Given this list of marker genes FGFR1, RUNX2, MAPK12, IGFBP3, CCND1, RARA, A2M, NFKB1, CD36, APOE, IGFBP5, HMOX1, PDGFRB, JUN, RB1, CDC25B, BTRC, SERPINA1, TNFRSF1A, BCL6, CXCL12, DCN, FAS, CD44, CDKN1B, APP, here is a description of the gene set: from publication Abraham RS, Ballman KV, Dispenzieri A, Grill DE, Manske MK, Price-Troska TL, Paz NG, Gertz MA, Fonseca R (PMID 15388584) Genes up-regulated in immunoglobulin light chain amyloidosis plasma cells (ALPC) compared to multiple myeloma (MM) cells. Human Gene Set: ABRAHAM_ALPC_VS_MULTIPLE_MYELOMA_UP species: Homo sapiens Immunoglobulin light chain amyloidosis (AL) is characterized by a clonal expansion of plasma cells within the bone marrow. Gene expression analysis was used to identify a unique molecular profile for AL using enriched plasma cells (CD138+) from the bone marrow of 24 patients with AL and 28 patients with multiple myeloma (MM) and 6 healthy controls. Class prediction analysis (PAM) revealed a subset of genes, which included TNFRSF7 (CD27), SDF-1, and PSMA2, that distinguished between these 2 groups with an estimated and observed accuracy of classification of 92%. This model was validated with an independent dataset of 11 patients with AL and 12 patients with MM with 87% accuracy. Differential expression for the most discriminant genes in the 12-gene subset was validated using quantitative real-time polymerase chain reaction and protein expression analysis, which upheld the observations from the micro-array expression data. Functional analyses using a novel network mapping software revealed a number of potentially significant pathways that were dysregulated in patients with AL, with those regulating proliferation, apoptosis, cell signaling, chemotaxis, and migration being substantially represented. This study provides new insight into the molecular profile of clonal plasma cells and its functional relevance in the pathogenesis of light chain amyloidosis.